Given this list of marker genes SSPN, RGS4, CSRP1, NFIX, CCDC80, SPARC, AGTR1, FBLN1, RRAS, BTG2, FSTL1, C1QTNF1, EMP1, LAMC3 (laminin subunit gamma 3), TIPARP, RGS16, LGALS1, MAP1B, RND3, PRSS23, TCF4, VIM, SFRP1 (NCBI Gene Id 6422), EDNRB, ACTN1, EFEMP1, COL4A1, ENG, COL4A2, PTGDS, MKNK2, TNS1 (tensin 1), CRYAB, LMNA, FILIP1L, SERPINE1 (serpin family E member 1), ITGB5, CCDC3, DCN, PTN, DSTN, LGALS3BP (NCBI Gene Id 3959), ARID5B, JUNB, ITGB1, HSPB1, SLC38A2, LRP1, CITED2, MATN2, LUM, MARCKS, CCBE1, CD63, CYBRD1, GPC6, IGFBP3, TPM4, PCDH9, CXCL12, MITF, ANTXR1, SOCS3, VCL (NCBI Gene Id 7414), COL3A1, MASP1, RN7SK, MYLK (NCBI Gene Id 50483), FBN1, ANK3, HGF, INMT, TMEM204, THBS2 (thrombospondin 2), COL14A1 (NCBI Gene Id 7373), ACTN4, C7, CH25H, CAV1, CSRNP1, MMP19, MXRA7, MGP, ATN1, IGFBP4, PDGFRA, TSC22D1, LTBP4, COL6A2, RBMS3, CTDSPL, FBLN2, CLDN11, C1S, OLFML3, PCOLCE, HLA-DRB1, CAVIN3, GSN, CALD1, ALDH1A1, DKK3, IL1RL1, COL6A1, FOSB, MFAP4, CCN2, ADAMTS1, EPAS1, DDR2, PHLDA1, PLCXD3, CEBPB, ADAMTSL2, C11orf96, PRELP, TIMP3, CCNI (cyclin I), ADAMTS2, NEXN, CEBPD, MYL9, LAMC1, DYNLL1, IGFBP7 (insulin like growth factor binding protein 7), CDKN1A, NR2F1, EGR1, CAVIN1, MYH10 (myosin heavy chain 10), COL5A1, GLUL, ZFP36, RBPMS, MT1M, IFITM2, ITGA9, DEPP1, GGT5, CFH, CCN1, ZFP36L1, TSC22D2, GPX3, PALLD, CCL2, TCEAL4, FOS, CDC42EP3, KAZN, AEBP1, TIMP1, SOD3, SERPINF1, GEM, THBS1, FBLN5, LAMB1, BMP2, DPT, TIMP2, QSOX1, COL6A3, DPYSL2, COL1A2, SYNPO2, RGS2, CD81, SRPX, IGFBP5, C1R, MYADM, SLIT3, KLF4, COLEC11, RBP1, ITM2C, H19, IER3, MAFF, CRISPLD2, FHL1, ITGA8, MMP2, ACTA2, BGN, IFITM3, COL1A1, CPXM2, NR2F2, NFIA, PROS1, THY1, MYC, here is a description of the gene set: studied in species Homo sapiens from publication Aizarani N, Saviano A, Sagar, Mailly L, Durand S, Herman JS, Pessaux P, Baumert TF, Grün D (PMID 31292543) Human Gene Set: AIZARANI_LIVER_C21_STELLATE_CELLS_1